The following is a description of a gene set: species: Mus musculus Any process that activates or increases the frequency, rate or extent of aspartic-type peptidase activity. Mouse Gene Set: GOBP_POSITIVE_REGULATION_OF_ASPARTIC_TYPE_PEPTIDASE_ACTIVITY, and this is the list of marker genes: Efna1, Grn, Ager, Efna3, Epha4 (Eph receptor A4), Lyn